Given this list of marker genes ZUP1, PPP1R18, GNL2, CHD7, AGO3, PSME2, SLC25A38, TBC1D1, PRCP, POU5F2, MS4A13, CDH22, HAAO, MRPL38, CCDC9, CD22, SAFB2, PDCD2, RLF, C1QTNF12, TNRC6A, SAFB, DPP6, SSBP1, MSI2, ELFN1, MAF1, ARHGEF10, MTERF3, MTLN, IPO8, PUS3, RAB26, SCYL2, PID1, E2F5, BANK1, OTOG, CCDC181, TMEM222, CYP2F1, VPS8, MAU2, SMN1, PDE4DIP, BRWD1, PAF1, F11, DNAH17, PBXIP1, PHAF1, OSBPL7, PIGP, SNORD104, B3GNT9, ATP6V0B, TREML1, KIAA1958, POLR3F, NLRP10, C19orf48P, STAT1, DAPP1, SLC13A1, AVPR1A, RNF216, PGAP1, CIB1, SLC38A7 (solute carrier family 38 member 7), CFAP161, NCOR2, ZPR1, MYH8, WDFY2, GRAMD1A, ZNF385C, TRIM7, RPL18A, MARCHF1, TARS1, REXO4, GUCY1A2, LUC7L3, CEP63, UBALD2, STAT6, TOMM34, GPCPD1, SCML4, ST3GAL1, NEDD9, MIX23, EGLN2, CCNT2, RETREG3, HEXA, C15orf61, TMEM86B, DCAF17, RFTN2, ABCF3, HTATSF1, NFE2L2 (NCBI Gene Id 4780), KLC2, CERS4, BIRC2, BSPRY, MBD5, SFSWAP, SGCA, DHX35 (NCBI Gene Id 60625), CAPN15, CYBB, THBS3, PIK3R1, TEX264, KYNU, LINC00612, TRMT1, STRN4, HS3ST1, ANPEP, TUT4, RAB6A, MARF1, ETNK1, APC, SLC39A7, ZMAT1, MYCBP2, PTPRCAP, STMP1, MINDY2 (MINDY lysine 48 deubiquitinase 2), CD40, HEG1, UBE3C, B3GAT3, FAM168A, KRTAP19-5, RPS19, BABAM2, STOML3, DPM2, ANKFY1 (NCBI Gene Id 57500), CELF3 (NCBI Gene Id 11189), BOD1L1, RPS25, MED1, CBFA2T3, PIK3CA, POLR3E, CFAP251 (cilia and flagella associated protein 251), CD69, SENP8, NELFB, RPS15A, ZC3H11A, TMOD4, SCAF8, LRIG2, NXPE3, SLAMF8, ZFP36L2, SNHG10, LENG8, GP1BB, LRRC74A, KIAA2013, FOXC1, B3GNTL1, DISP1, LAMA2, IMP3, PFDN5, ZNF655, PRR23A, MINDY1, OTUD5, SNX29, ENO4, DOLK, RPL37A, UROS, BSDC1, OSCP1, PKN1, RNPEPL1, CYP2U1, GATA4, SELENOO, ERAL1, LRP6, RBMX, SKAP2, EBF1, RSRC2, PTPRN, ZNF638, KAT8, CREBZF, here is a description of the gene set: species: Homo sapiens Upon immunization with a T cell dependent antigen naive follicular B cells (Fo) are activated and a germinal center reaction is induced. Within the next 2 weeks large germinal centers develop where the process of affinity maturation takes place. To analyze the gene expression profile of resting and activated B cells, follicular B cells (Fo), B cells from early (GC1) and late germinal centers (GC2) were isolated and their gene expression profile compared. Genes up-regulated in comparison of naive follicular B cells versus early germinal center (GC) B cells. from publication Wilke G, Steinhauser G, Grün J, Berek C (PMID 20518031) Human Gene Set: GSE28237_FOLLICULAR_VS_EARLY_GC_BCELL_UP